Given this list of marker genes Myocd, Cdk5rap1 (NCBI Gene Id 66971), Nr2f2, Lats2, Wee2, Tfap4, Plk1, Cdkn2c, Inca1, Pten, Cdkn2a, Cdkn1b, Casp3, Cdkn1c, Hexim2, Kat2b, Tnfaip3, Men1, Cdkn1a, Fbxo7, Hhex, Apc, Lats1, here is a description of the gene set: Mouse Gene Set: GOBP_NEGATIVE_REGULATION_OF_CYCLIN_DEPENDENT_PROTEIN_KINASE_ACTIVITY Any process that stops, prevents or reduces the frequency, rate or extent of cyclin-dependent protein kinase activity. studied in species Mus musculus